Given this list of marker genes FGFR2, FGFR1, HOXA13, GDF5, COL2A1, EIF2AK3, PHF6, here is a description of the gene set: Shortening of all middle phalanges of the fingers Short, hypoplastic middle phalanx of finger, affecting all fingers. species: Homo sapiens Human Gene Set: HP_SHORTENING_OF_ALL_MIDDLE_PHALANGES_OF_THE_FINGERS